Given this list of marker genes TMEM88, RAB31, ADCYAP1R1, JAZF1, PROSER2, SRSF4, SPATS2L, CSNK1D, GPC1 (NCBI Gene Id 2817), CAPRIN1, UBE2R2, NFAM1, STXBP5L, TMEM170A, KRCC1, RIMS3, USP31 (ubiquitin specific peptidase 31), LUZP1, MDM4, ZC3H12C, C3orf80, GTSE1, EMC1, APOBEC3F, MTR, RNF44, LONRF2, PLXNA1, TNRC6B, RBMS2, THAP9, LIMCH1, SEPTIN3 (septin 3), NALF1 (NCBI Gene Id 731895), HID1, SPTSSB, PCYT1B, TANGO2, PRND, VASH1, CARMIL1, SPN, S100A16, MPRIP, SAP18, USP9X, NKIRAS2, FOXP4, RAP1GDS1, NLRP1, RNF222, EEIG1, ORAI2, NIPAL3, ARPC2, SNX1, HSDL2, MIDEAS, MFSD11, DOK4, LARS1, ZC3H12A, GRAMD1B, TEP1, WWC3, SLCO5A1, RAB22A, MED22, PHF21A, TSC1, CHD1, CA8, RNF168, HEYL, KSR2, RBPJ, VCAN, here is a description of the gene set: from publication Chen Y, Wang X (PMID 31504780) Genes predicted to be targets of miRBase v22 microRNA hsa-miR-6849-3p in miRDB v6.0 with MirTarget v4 prediction scores > 80 (high confidence targets). Human Gene Set: MIR6849_3P studied in species Homo sapiens